The following is a description of a gene set: The effect of human cytomegalovirus (HCMV) infection on cellular mRNA accumulation was analyzed by gene chip technology. During a 48-h time course after infection of human diploid fibroblasts, 1,425 cellular mRNAs were found to be up-regulated or down-regulated by threefold or greater in at least two consecutive time points. Several classes of genes were prominently affected, including interferon response genes, cell cycle regulators, apoptosis regulators, inflammatory pathway genes, and immune regulators. The number of mRNAs that were up-regulated or down-regulated were roughly equal over the complete time course. However, for the first 8 h after infection, the number of up-regulated mRNAs was significantly less than the number of down-regulated mRNAs. By analyzing the mRNA expression profile of cells infected in the presence of cycloheximide, it was found that a minimum of 25 mRNAs were modulated by HCMV in the absence of protein synthesis. These included mRNAs encoded by a small number of interferon-responsive genes, as well as beta interferon itself. Cellular mRNA levels in cytomegalovirus-infected cells were compared to the levels in cells infected with UV-inactivated virus. The inactivated virus caused the up-regulation of a much greater number of mRNAs, many of which encoded proteins with antiviral roles, such as interferon-responsive genes and proinflammatory cytokines. These data argue that one or more newly synthesized viral gene products block the induction of antiviral pathways that are triggered by HCMV binding and entry. studied in species Homo sapiens Genes up-regulated in primary fibroblast cell culture after infection with HCMV (AD169 strain) at 48 h time point that were not up-regulated at the previous time point, 24 h. from publication Browne EP, Wing B, Coleman D, Shenk T (PMID 11711622) Human Gene Set: BROWNE_HCMV_INFECTION_48HR_UP, and this is the list of marker genes: SNX4, PIP5K1A, RUNDC3B, BRCA1, CKS2, ZNF202, ERVW-1, MNDA, ZNF20, RAB29, MAD2L1, CCDC69, ANXA3, PTPRR, RRAD, TLE1, IER3, DHX38, MSH2, NFATC2IP, POLE2, MRS2, PDE8B, CCNE1, NTRK3, ABCB9, GPR18, RGS16, ATG12, CD55, EPM2A, SKIL, PPT1, ABCB7, H2AC18, USP1, CPE, MAGOH, PAWR, NUP160, RBP4, FAM13A, CTH, KLRG1, CELSR2 (cadherin EGF LAG seven-pass G-type receptor 2), CLN3, NUP205, SORD, PTGER3, NEMP1, ITPR1, BAMBI, AMD1, HMGN3 (high mobility group nucleosomal binding domain 3), SRSF8, CD2AP, GABPA, PPP2R1B, CREBZF, POLA2, ITPR2, LIFR, PC, ABCG1, ZNF330, PPT2, RAD51D, EDN3, IFI27, EZR, TMOD1, SLC22A5, GAB1, EEF1E1, IGFBP2, HADH, TYRO3, HAT1, ATP6V1B2, NFATC3, IFI30, OIP5, RUNX3, GRIA1, HSF4, TMEM106C, CYP3A4, CCNF, SLC39A14, CD24, AKAP10, SNAPC1, POLR2H, MT4, CYP1A1, POU1F1, FBXO28, APOM, COL9A3, ONECUT1, NFIA, LAMA5, LMO2 (LIM domain only 2), HSPA2, GEM, C5orf22, BTF3P12, PIK3R3, GGH, VIL1, SLC6A12, PRPS2, MAN2A2, ZC3HAV1, SPINK1, PLXDC1, ATF3 (activating transcription factor 3), GABBR1 (gamma-aminobutyric acid type B receptor subunit 1), FUCA1, RNF44, CDC7, GGCT (gamma-glutamylcyclotransferase), ZBTB1, DNAJC7, AJAP1, TNP1, GREB1, RFC3, RGS6, RFC4, SLPI, PSMD11 (NCBI Gene Id 5717), MBD4, E2F5, MLLT11, ZNF101, PPM1H, IL18R1, DHX9, OTUD3, ELAC2, ATP11A, POLR3F, NUP153, GADD45B, PPP3CB, PDK3, MTSS1, PTGES, CTNNA2, ZNF529, LILRB4, SLC25A5, BRME1, LRP4, SNCA, RET, GPD2, PCGF3, COBL, H2BC5, CASP10, IL24, PFKP, H2AZ1, DPT, ZNF365, TPST2, SAP30, PLCG2, BMP6, FUT9, CHST1, MTMR9, CXCR4, IFNAR2, FNBP1L, CALCRL, TOR1B, FRRS1L